The following is a description of a gene set: studied in species Mus musculus Mouse Gene Set: GOBP_LEUKOCYTE_APOPTOTIC_PROCESS Any apoptotic process in a leukocyte, an achromatic cell of the myeloid or lymphoid lineages capable of ameboid movement, found in blood or other tissue., and this is the list of marker genes: Ccl19-ps3, Cxcl12, Fnip1, Nfkbiz, Mir92-2, Ghsr, Mir19a, Ifng, Ccr7, Ccl19-ps5 (NCBI Gene Id 100039789), Traf3ip2, Kdelr1, Siva1, Axl, Tnfrsf21, Mir17, Fas, Cd74, Il2, Ccl21f, Anxa1, Bcl2l11, Adam17, Bcl2, Prelid1, Bcl11b, Itpkb, Ebf4, Cd3g, Hsh2d, Nf1, Gimap8, Nod2, Selenos, Akt1, Sirt1, Rapgef2, Bmp4, Trp53, Adam8, Ripk1, Serpinb9, Cd274, Cd27, Mir18, Pik3cb, Ccl19-ps4, Prkcq, Lgals3, Kitl, Casp7, Tgfb2, Nfkbid, Hcls1, Ormdl3, Mir92-1, St6gal1, Ptcra, Mir19b-1, Mir20a, Mif, Jak3, Fcmr, Irs2, Mertk, Gas6, Il2ra, Slc7a11, Lmbr1l, Gli3, Crkl, Pkn1, Mef2c, Il18, Wnt5a, P2rx7, Gpam, Ripk3, Ccl5, Ido1, Ccl21a, Mir363, Ccl21b, Cd47, Prkd2, Birc7, Mir106b, Noc2l, Nr4a3, Rag1, Il10 (interleukin 10), Il3, Hcar2, Fcer1g, Chek2, Mir25, Stat5a, Cd24a, St3gal1, Blm, Zc3h8, Gm14461 (NCBI Gene Id 78158), Arg2, Bcl3, Plekho2, Slc46a2, Il21, Dnaja3, Foxp1, Ccl21e, Itgam, Tnfsf4, Myc, Pik3cd, Mir18b, Fcgr2b, Tsc22d3, Aurkb, Pnp, Lyn, Bbc3, Ccl21d (C-C motif chemokine ligand 21D), Lipa, Ccr5, Pten (NCBI Gene Id 70161), Mir19b-2, Bcl2l1, Rps6, Ada, Perp, Siglec1, Hif1a (hypoxia inducible factor 1, alpha subunit), Cdkn2a, Bak1, Casp8, Fadd, Mir106a, Pdcd7, Dock8 (NCBI Gene Id 76088), Ccl19-ps6, Rorc, Bcl2a1a, Ccl19-ps1, Ccl19, Vhl, Efna1, Mir20b, Pdcd1, Il7r, Casp3, Mir93, Bax, Fasl, Dffa, Slc39a10, Pip, Bcl10, Cxcr2, Casp9, Tnfrsf4, Kifap3, Il6, Cd44